The following is a description of a gene set: Human Gene Set: GOBP_POSITIVE_REGULATION_OF_STEROID_HORMONE_SECRETION Any process that activates or increases the frequency, rate or extent of steroid hormone secretion. studied in species Homo sapiens, and this is the list of marker genes: CRH, RETN, C1QTNF1, GAL, GHRL, SPP1, GALR1, CYP19A1, NKX3-1, BMP6, TAC1, DAB2, ECRG4